Given this list of marker genes ASCC1, RN7SL518P, SNORA71, RPS15AP28, RNU6-697P, RNU6-673P, DUSP13B, ANAPC16, YY1P1, RPL26P6, C1DP2, COL13A1, KCNMA1-AS2, PPA1, C1DP4, SFTPA1 (NCBI Gene Id 653509), SRGN, NUTM2E, FAM32CP, MRPS16, TMEM254-AS1, ATP5MC1P8, IMPDH1P5, VPS26A, TMEM256P1, DUSP8P5, MTND2P15 (MT-ND2 pseudogene 15), PPP3CB-AS1, TSPAN15, FUT11, DLG5, RN7SL284P, SYNPO2L-AS1, NDST2, FAM149B1, RPL5P26, PPP3CB, FAM241B, NUDT13, CTSLP6, RPS26P40 (ribosomal protein S26 pseudogene 40), SNX19P4, CHST3, PLAC9 (placenta associated 9), ENSG00000295562, UNC5B-AS1, DDIT4, NUTM2B, RPL17P50 (NCBI Gene Id 90551), RNU6-805P, EIF4EBP2, RNU6-883P, CHCHD1, MAT1A, RPL39P25, TMEM254, HKDC1, HK1, LINC02636, VDAC2, MICU1, MCU, SNORA11F, RPL15P14, C10orf105, ZNF519P1 (zinc finger protein 519 pseudogene 1), EIF5AP4, C10orf55 (chromosome 10 putative open reading frame 55), MTATP6P23, ANXA7, RPS12P17, POLR3DP1, SGPL1, CEP57L1P1, SLC29A3, HMGA1P5, CAMK2G, NODAL, RN7SL840P (RNA, 7SL, cytoplasmic 840, pseudogene), ACTBP14, VCL, BMS1P21, SAR1A, RPS26P42 (NCBI Gene Id 100271568), LINC00857, RPS12P18, NUTM2B-AS1, MBL3P, USP54, P4HA1, SFTPD-AS1, GLUD1P3 (glutamate dehydrogenase 1 pseudogene 3), AGAP5, RNU7-38P, KAT6B, ENSG00000298084, SYNPO2L, PCBD1, ZMIZ1-AS1, RPL22P18, BMS1P4-AGAP5, ENSG00000293221, KCNMA1, SUPV3L1, NPM1P24, NPAP1P2, ENSG00000289607, RNA5SP321, MED28P1, SPA17P1, ZNF503, ZSWIM8-AS1, MIR4676, RAB5CP1, MBL1P, MRPL35P3, C1DP3, RNA5SP320, DUSP13A (dual specificity phosphatase 13A), LRMDA, SAMD8, MACROH2A2, TIMM9P1, KIFBP, RNU6-833P, NEUROG3, MIR7152, SFTPD, ZNF503-AS1 (NCBI Gene Id 253264), PPIF, COMTD1, DPY19L2P5, NDUFA8P1, TPRX1P1, CDH23, PSAP, CALM2P2, GNAI2P2, ADAMTS14, LINC02651, DDIT4-AS1, OIT3, RPS12P2, ENSG00000229261, SFTPA2, DDX21, SEC24C, MYOZ1, KCNMA1-AS3, CDH23-AS1, TYSND1, VSIR, ENSG00000306492, ZNF503-AS2, MSS51, DNAJB12, STOX1, TACR2 (tachykinin receptor 2), CAMK2G-AS1, COX7CP4, RNU6-571P (RNA, U6 small nuclear 571, pseudogene), PLA2G12B, ADK, MTCO2P23, H2AZP5, ZMIZ1, LRRC20, ENSG00000272447, SPOCK2, PRF1, MIR606, UNC5B, EIF4A2P2, ENSG00000200294, PLAU, RPS26P41, HMGN2P34, BMS1P4, DDX50, ANXA11, BEND3P3, NPFFR1, PPIAP13, ZCCHC24, LINC02622, AP3M1, ZNRF2P3, TBATA, SFTPA3P, RPS25P9, COX6CP15, RPS24, KCNMA1-AS1, ATP5MC1P7, AIFM2, CFAP70, PGGT1BP2, POLR3A, ENSG00000289362, RPSAP6, MTCO1P23, LINC00856, ECD, DNAJC9-AS1, DUSP29, ZSWIM8, DLG5-AS1, MTND1P20, DNAJC9, LINC02679, PALD1, RNU6-1266P, EIF5AL1, here is a description of the gene set: Human Gene Set: chr10q22 species: Homo sapiens